Given this list of marker genes Sphk2, Pik3r5 (NCBI Gene Id 320207), Dgkh, Pi4ka, Pip5kl1 (NCBI Gene Id 227733), Pik3r1, Pi4kb, Pip5k1b (NCBI Gene Id 53355), Pik3cb, Pip5k1a, Pi4k2a (phosphatidylinositol 4-kinase type 2 alpha), Dgki, Pip4k2a, Atm, Pik3cd, Sphk1, Dgkd, Dgkg, Pik3c2a, Dgkk, Pik3r6, Dgka, Dgkb (NCBI Gene Id 217480), Dgkz, Pip4k2c, Pik3c2b, Pik3c3, Pik3cg, Cerk, Pikfyve, Pik3c2g, Pip5k1c, Ipmk (inositol polyphosphate multikinase), Pik3ca, Pi4k2b, Pip4k2b (phosphatidylinositol-5-phosphate 4-kinase, type II, beta), Dgkq, Dgke, Pik3r2, Cerkl, Pik3r3, Agk, here is a description of the gene set: Mouse Gene Set: GOMF_LIPID_KINASE_ACTIVITY Catalysis of the phosphorylation of a simple or complex lipid. species: Mus musculus